The following is a description of a gene set: Human Gene Set: GOBP_LEPTIN_MEDIATED_SIGNALING_PATHWAY The series of molecular signals initiated by leptin binding to its receptor on the surface of a cell, and ending with the regulation of a downstream cellular process, e.g. transcription. Leptin is a hormone manufactured primarily in the adipocytes of white adipose tissue, and the level of circulating leptin is directly proportional to the total amount of fat in the body. studied in species Homo sapiens, and this is the list of marker genes: UGCG, STAT3, LEP, BBS2, LEPR (NCBI Gene Id 3953), BBS4, SIRT1, MT3, ADIPOR1, MKKS